Given this list of marker genes F2, CTSG, F2RL1, ELANE, TUSC2, SCNN1B, TREM1, NCF1, NLRP6, AZU1, CXCL6, DAO, MYD88, PCYOX1L, here is a description of the gene set: Human Gene Set: GOBP_NEUTROPHIL_MEDIATED_KILLING_OF_BACTERIUM studied in species Homo sapiens The directed killing of a bacterium by a neutrophil.